The following is a description of a gene set: Human Gene Set: GSE43955_10H_VS_30H_ACT_CD4_TCELL_UP species: Homo sapiens Despite their enormous importance, the molecular circuits that control the differentiation of Th17 cells remain largely unknown. Recent studies have reconstructed regulatory networks in mammalian cells, but have focused on short-term responses and relied on perturbation approaches that cannot be applied to primary T cells. Here, we develop a systematic strategy – combining transcriptional profiling at high temporal resolution, novel computational algorithms, and innovative nanowire-based tools for performing gene perturbations in primary T cells – to derive and experimentally validate a temporal model of the dynamic regulatory network that controls Th17 differentiation. The network is arranged into two self-reinforcing and mutually antagonistic modules that either suppress or promote Th17 differentiation. The two modules contain 12 novel regulators with no previous implication in Th17 differentiation, which may be essential to maintain the appropriate balance of Th17 and other CD4+ T cell subsets. Overall, our study identifies and validates 39 regulatory factors that are embedded within a comprehensive temporal network and identifies novel drug targets and organizational principles for the differentiation of Th17 cells. Genes up-regulated in CD4 T helper cells Th0: 10h versus 30h. from publication Yosef N, Shalek AK, Gaublomme JT, Jin H, Lee Y, Awasthi A, Wu C, Karwacz K, Xiao S, Jorgolli M, Gennert D, Satija R, Shakya A, Lu DY, Trombetta JJ, Pillai MR, Ratcliffe PJ, Coleman ML, Bix M, Tantin D, Park H, Kuchroo VK, Regev A (PMID 23467089), and this is the list of marker genes: LPL, PCDH7, MYBL2, DHX15, AOC1, ZNF274, SH3BGRL3, ST3GAL5, TPGS2, NKIRAS1, IGSF8, CXCR3, TSKS, CORO1A, PNN, EPC1, RPL39, KGD4, CS, VEGFC, HAPSTR1, S1PR3, GDF3, LMO4, SCN1B, DNAJA1, SAP30L, TRIM21, LCP1, TUBB, TRIM47, REPS1, CTSH, RFK, SPP1, LY86, PGK1, NDUFC2 (NADH:ubiquinone oxidoreductase subunit C2), C3AR1, TRIM27, DLGAP4, NECTIN2, CLIP3, SH3BP2, IL1A, IPO5, PSEN2, NR1H3, BCL2L1, RPP25L, USP25, EDN3, POU2AF1, LYSMD2, RPRD1A, PLAUR, HLA-DRB1, PPP1R15A, PRKCD, TMPRSS15, HAS1, TRPC6, CDK4, MARCO, ZNF385A, PCGF5, VCAM1, FGF4, C1QB, CCNG2, ARPC5, BAD, LRP5, IFIT2, CAT, TMEM71, INTS14, GLRX, PADI1, CES1, PRM3, CD3E, TOM1L1, VASP, TPSB2, TANGO2, MX2, CD320, AIF1, E2F8, ETS2, SELENOV, HTR1F, CXCL3, P4HA2, CKAP5, NCF1, AMZ2 (NCBI Gene Id 51321), ID3, INPP4A, C1QA, IL10RA, FHL2, SLFN12, KL, LOXL1, IL6, HSPB8, KCNA3, STAU1, PCDH12, PRSS12, CPXM1, ABCD3, CAV1, ITIH2, NUDT4 (nudix hydrolase 4), GRIN2D, FLNB, SERPINE2, TMED1, SRA1 (steroid receptor RNA activator 1), BCL2L13, SYT2, HSPB2, KRT77, PPT2, GDNF, EIF2D, PCSK7, MPZL2, TNFRSF11B (NCBI Gene Id 4982), TUBA8, ABCB4, RSAD2, PCYT1A, C9orf72, MSN, ALPL, ENOPH1, CDKN1C, CPD, PLAT, OSBPL11, ENO2, PAM, SNTB1, PTCH1, ADORA1, NAB2, STX6, PHKG1, MAPK14, LANCL2, CH25H, OPRK1, NUDCD2, HSPA1A, SSTR3, F11R, PLPP3, PEX14, CD5L, CCNF, PPA1, TAOK3, SCHIP1, CCL13, UIMC1, TLR6, RNF103, NUMB, DYM, CCL22, SMYD5, KCNJ1, TH, PLXNA3, LYST, UPP1, CXCL13, INPP5D, TNF, TNNT2, COLQ, IRF5, PIGR, PELI1, CPEB1, YWHAG, FHL1, EFNA3, MYO6, ANXA5, HSPA1B, CACNB3, MRPS2, KRT27, ITCH, CDH1